The following is a description of a gene set: Basal ganglia calcification The presence of calcium deposition affecting one or more structures of the basal ganglia. Human Gene Set: HP_BASAL_GANGLIA_CALCIFICATION studied in species Homo sapiens, and this is the list of marker genes: SLC46A1, SLC20A2, ERCC8, JAM2, ERCC3, RBBP8, PDGFB, MT-CO3 (mitochondrially encoded cytochrome c oxidase III), GJA1, MT-TF, MT-ND1, MT-TQ (mitochondrially encoded tRNA-Gln (CAA/G)), MT-ND4, MYORG, AP1S2, MT-CO2, MT-TL1, SNORD118, PDGFRB, ACVR1, RNASEH2B, DNM1L, NAA60, MT-ND6, TYROBP, MT-ND5, PSMG2, MT-TS2, RNU7-1, GATA3, TREX1, MT-TH, ERCC4, CA2, XPR1, ESAM (endothelial cell adhesion molecule), CYP2U1, DENND5A, FAM111A, TREM2, GNAS, MT-TW, GNA11, SAMHD1, OPA1, IFIH1, PSMB8, MT-CO1 (mitochondrially encoded cytochrome c oxidase I), EXOSC2, PSMB9, ISG15, CASR, SLC25A46, ERCC6, LSM11